The following is a description of a gene set: part of: Influenza Viral RNA Transcription and Replication species: Homo sapiens Reactome Pathway: cRNA Synthesis Synthesis of full length complementary viral RNA (cRNA) requires that vRNA transcription initiates without the help of a host cell methyl RNA cap as a primer, and that it proceeds to the 5' end of the vRNA template without stuttering on the sub-terminal poly-U sequence. Free viral NP protein appears to play a central role in enabling both of these features of cRNA synthesis, although the molecular details of its role remain unclear., and this is the list of marker genes: PB1, PA, NS, PB2, NP